The following is a description of a gene set: Mouse Gene Set: GOBP_REGULATION_OF_INTRINSIC_APOPTOTIC_SIGNALING_PATHWAY_IN_RESPONSE_TO_DNA_DAMAGE_BY_P53_CLASS_MEDIATOR species: Mus musculus Any process that modulates the frequency, rate or extent of intrinsic apoptotic signaling pathway in response to DNA damage by p53 class mediator., and this is the list of marker genes: Hnrnpk, Cd74 (CD74 antigen (invariant polypeptide of major histocompatibility complex, class II antigen-associated)), Zfp385a, Mif, Knl1 (kinetochore scaffold 1), Trp73, Atad5, Muc1, Sirt1, Rpl26, Ell3, Cd44, Kdm1a, Steap3, Bcl2l12 (BCL2 like 12), Triap1, Marchf7